Given this list of marker genes DFFB, ACIN1, TOP2A, ERN2, GPER1, here is a description of the gene set: The compaction of chromatin during apoptosis. Human Gene Set: GOBP_APOPTOTIC_CHROMOSOME_CONDENSATION studied in species Homo sapiens